The following is a description of a gene set: studied in species Mus musculus The transport of lipids between membranes in which a lipid molecule is transported through an aqueous phase from the outer leaflet of a donor membrane to the outer leaflet of an acceptor membrane. This process does not require metabolic energy and can be either spontaneous or mediated by lipid transfer proteins (LTPs). Mouse Gene Set: GOBP_INTERMEMBRANE_LIPID_TRANSFER, and this is the list of marker genes: Cert1, Esyt1, Triap1, Gltp, Pitpnm1, Pitpnc1, Cidec, Pitpnb, Cptp, Cidea, Osbpl8, Atg2b, Osbpl5, Gltpd2, Pitpna, C2cd2l, Osbpl2, Mttp, Cideb (NCBI Gene Id 68665), Pltp, Scp2, Tnfaip8l3, Prelid1, Bltp1, Ttpa, Bltp3b (NCBI Gene Id 97652), Plekha8, Pitpnm2, Abca3, Atg2a